The following is a description of a gene set: Genes predicted to be targets of miRBase v22 microRNA mmu_miR_5104 in miRDB v6.0 with MirTarget v4 prediction scores > 80 (high confidence targets). Mouse Gene Set: MIR_5104 studied in species Mus musculus from publication Chen Y, Wang X (PMID 31504780), and this is the list of marker genes: Wdr44, Mdga1, Fbxl14, Chfr, AA986860, Eif3j2, Kif3c, Usp32 (ubiquitin specific peptidase 32), Kif21b, Slc6a1, Nufip2, Tenm3, Lgr4, Cdh2, Nup50, Adam12, Htr2c, Rnf41, Tulp3, Vsig8, Rps6kb1, Tanc2, Adipor2 (NCBI Gene Id 68465), Asxl2, Prkd3, Ankrd27, Pacc1, Mbnl2, Kcnd2, Dcun1d1, Plxnc1, Adipor1, Nkiras1, Rnf103, Kcnip3, Frmd6, Snx4, Plekhg1 (NCBI Gene Id 52522), Rimbp2, Sh3kbp1, 2510009E07Rik, Pcnp, Ccdc6, Onecut2, Insyn2b, Slf2, Slc6a6, Fam20b, Kirrel3, Gabrb2, Eif3j1, Rasa1, Cep97, Ebf2, Exd2, Lmo7, Reln, Trps1, Epc1, Gabpa, Ntng1, Glce, Scai, Sh3rf1, Psmd14, Sfxn5, Lrrc59, Dazap1, Rhoq, Gnb1, Nhsl2 (NCBI Gene Id 68850), Pxn, Qrfp, Gpr176 (NCBI Gene Id 381413), Eya1, Thoc2, Fut4, Pum2, Taok3, Plpp3, Gfpt1, Mospd1, Mtf2, Crh, Septin11, Cemip, Grk3, Cacnb4 (calcium channel, voltage-dependent, beta 4 subunit), Ppp2cb, Cntn1, Rsf1, Pik3r1, Zmat4, Mier3, Tigd4, Nav3, Trpc3, Ago1, Slain2, Ogt, Prelid1, Syt1, Fbxl2, Slc16a10, Eif4e3, Naa15, Nxpe2, Zfx, Fbxl5, Hectd2, Nkain2, Rgs17, B4galt6, Clcn3, Qtrt2, Atosa, Reps2, Zbtb11, Ret (ret proto-oncogene), Fchsd2, Mindy2, Eif2ak3, Kcnq5, Kdm3b, Zfp697, Ermn, Trak2 (trafficking protein, kinesin binding 2), Lgalsl, Kcnk2, Ell2, Oxsr1, Diras1, Bbx, Extl3, Shisa9, Cdkn1b, Cntnap2, Six4, Rnf114, Lasp1, Ank1, Sorbs1, Megf10, Syt13, Piezo2, Tmem25, Sulf2, Hexim1, Klhl13, Kalrn, Hecw1